The following is a description of a gene set: Mouse Gene Set: REACTOME_HDR_THROUGH_SINGLE_STRAND_ANNEALING_SSA studied in species Mus musculus HDR through Single Strand Annealing (SSA), and this is the list of marker genes: Topbp1, Rpa1, Hus1, Mre11a, Rpa3, Ercc1, Bard1, Rbbp8, Ercc4, Rad52, Dna2, Exo1, Rad51, Rhno1, Rpa2, Kat5, Rad17, Rad9b, Atm, Brip1, Rmi2, Rad1, Rad50, Rfc2, Blm, Top3a, Brca1, Rfc5, Rfc3, Nbn, Rfc4, Atrip, Rad9a, Abl1, Rmi1, Wrn